Given this list of marker genes C4BPB, FGB, ANXA5, PLAUR, NFE2, F2, PLAT, VWF, ITGB3, F13A1, MST1, CD59, SERPINE1, THBD, IL11, SERPIND1, ADORA2A, F8, F3, TFPI2 (tissue factor pathway inhibitor 2), ITGA2, EFEMP2, FGG, SERPINC1, ANXA8L1, F10, MMRN1, FGA (fibrinogen alpha chain), PLAU, PROC, PLSCR1, PLG, F12, here is a description of the gene set: Blood coagulation factors. species: Homo sapiens Human Gene Set: MODULE_131